Given this list of marker genes Slc51b, Il15, Pomt2 (protein-O-mannosyltransferase 2), Ramp1, Chp1, Golga2, Pomt1, here is a description of the gene set: Mouse Gene Set: GOBP_POSITIVE_REGULATION_OF_PROTEIN_GLYCOSYLATION studied in species Mus musculus Any process that activates or increases the frequency, rate or extent of the glycosylation of one or more amino acid residues within a protein. Protein glycosylation is the addition of a carbohydrate or carbohydrate derivative unit to a protein amino acid, e.g. the addition of glycan chains to proteins.